The following is a description of a gene set: The successive addition of amino acid residues to a nascent polypeptide chain during protein biosynthesis. Human Gene Set: GOBP_TRANSLATIONAL_ELONGATION studied in species Homo sapiens, and this is the list of marker genes: RNF25, GFM2, RPLP1, EIF5A2, SARS1, GIGYF2, ABTB1, ELAC1 (elaC ribonuclease Z 1), GTPBP1, ZNF598, TRNT1, RPLP2, USP16, EEF1A1P5, EIF5A, DIO2, LTN1, ASCC2, CPEB2, TRIP4, EEF1D, RCHY1, SELENOT, EEF1A2, GCN1, UFL1, ALKBH1, MRPL58, RNF14, GFM1 (NCBI Gene Id 85476), EIF5AL1, PELO, MTRFR, DDRGK1, CDK5RAP3 (NCBI Gene Id 92989), UFSP2, TCF25 (transcription factor 25), SKIC3, CPEB3, EEF1B2, PTRH1, EEFSEC, EIF4A3, ANKZF1, SKIC2, USP10, EEF1G, SMYD5, SECISBP2, SEPSECS, AARS1, SAYSD1 (NCBI Gene Id 55776), ASCC3, SHFL, TRNAU1AP, TUFM, TSFM, SRP9, EFL1, ABCE1, MRPL44, RACK1, SKIC8, METTL18, GTPBP2, EEF2K (eukaryotic elongation factor 2 kinase), EEF1A1, EIF4E2, KLHDC10, NEMF, EEF2, MTRES1, HBS1L